The following is a description of a gene set: This event has been computationally inferred from an event that has been demonstrated in another species.<p>The inference is based on the homology mapping from PANTHER. Briefly, reactions for which all involved PhysicalEntities (in input, output and catalyst) have a mapped orthologue/paralogue (for complexes at least 75% of components must have a mapping) are inferred to the other species. species: Mus musculus Reactome Pathway: Retrograde transport at the Trans-Golgi-Network part of: Intra-Golgi and retrograde Golgi-to-ER traffic electronically inferred by orthology from the curated human pathway, and this is the list of marker genes: Igf2r, Vps54, Cog7, Cog8, Nsf, Plin3 (perilipin 3), Gcc1, Golga4, Rab9b, Arfip2, Rab6a, Vamp4, Usp6nl, M6pr